Given this list of marker genes USPL1, RNF167, HMGB2, PIP4P1, ARHGEF9, AASS, EXOSC3, TPM3P9, SNAI2, EIF4A1P7, SPATA13, NIF3L1, ZNF569, TPI1P2, TXNDC12, IMP3, IFT27, SEC63, RHOA, MAP3K3, MBIP, CCNT2-AS1, FOXC1, NCAPD2, NGDN, RGMB, WDR81, PIK3R3 (phosphoinositide-3-kinase regulatory subunit 3), KHSRP, H2BC5, TNFAIP8, EN1, HCP5, PSMC4, NOP16, MAP3K13, PPP2R1A, NME1, WDR36, EXOC4, CASP8AP2, ENSG00000255240, ATF2, PGD, BEX4 (NCBI Gene Id 56271), CCDC51, MPC2, NME1-NME2, YIF1B, CREB3L4, DRC12, STX16-NPEPL1, SLC38A2, ST6GALNAC2, PAPSS2, PTTG1, RBBP4, HSPB6, AAMDC, RBM4, MSTO1, COPS4, RPL5, MAP3K9-DT, VPS51, ZNF302, CERNA3, LINC02939, UBE2D3-AS1, ATF7-NPFF, UBP1 (NCBI Gene Id 7342), LINC00240, TCP1, WDR62 (WD repeat domain 62), ZC3H12C, MIR933, DDX5, SLC25A25, SPTLC1P1, KDM3A, ZNF217, MTMR4, POC5, PHTF2, EFCAB11, TNFRSF10B, ST20, IER5L, IDI1, LINC01013, PSMA1, APOBEC3H, NEDD9, MRPS14, SSX2IP, TEPSIN, ZNF700, MGAM2, SNAI3-AS1, ABCA11P (ATP binding cassette subfamily A member 11, pseudogene), MTRF1L, LINC00173, C16orf95-DT, BPGM, SNHG19, LENG8-AS1, SRSF1, GABPA, RND1, KIAA1586, RBM15-AS1, MAP3K7, RAB5B, FAM228B, RFX1, PMS2P4, MTF2, SLC12A2, TOP2A, IFIT1, IVD, KCTD5, ADAMTS17, CCDC71L, MYO19, LINC00910, IBTK, ZNF714 (NCBI Gene Id 148206), NLK, ZNF678, C1QTNF6, HOMER1, TOMM20, MED23, STAG3, COX17, LINC01596, RGMB-AS1, ETV4, RPS24, PDP2, MTND4P34, PSENEN, XBP1, RRAGAP1-AS1, RTTN, CDKN2D, PQBP1, COMMD4, UNK, BRIP1, MXD3, OGG1, MEIOC, TMA7, ZNF221 (NCBI Gene Id 7638), TNKS, RNU4-71P, KCNC3, ILF3 (interleukin enhancer binding factor 3), EGLN2, HACL1, ACSF2, ARL15, ZNF138, SPTBN4, SMAD6, PHPT1, TRMT10C, YJU2, CCNB1IP1 (cyclin B1 interacting protein 1), DLX6, PDXP, RBM42, TRIR, GNAI2, RNU5E-4P, ZDHHC24, MCM3AP, NSUN6, MSH3, NME7, HLA-F, RPL37, BAZ2B, RMI1, BAG2, GBF1, SNORA21, LYPD6, FAM76A, PRRG2, PLEKHG2, PRRT2, PPP6R3, TNPO3, LINC02356, PMEL, NFIA, MALSU1, SNHG10, RAB27A, CBLB, PTK2B, EPHX1, ZNF611, ENSG00000207751, ATF7IP2, TIMM17B, CCAR1, ZNF232, PCLAF, TMEM60, ZNF117, PXDC1, ZNF416, ZFP28-DT, ANAPC5, RPS19, UBASH3B, TMX1, LINC01232, CNNM3, LRP10, TNFRSF10D, CEP57, TBC1D31 (NCBI Gene Id 93594), NLGN2, SPTLC2, SCOC, NKX3-2, TJP3, SNAP47, MAFB, DHFR, ZNF93, ARL2BPP3, FKBP14, SRGAP3, CLCN3 (chloride voltage-gated channel 3), CDK19, PAXBP1, LGR4, FAM13A, RNU7-1, SLC25A11, ZNF230-DT, SF3A3, ZDHHC12, H2AC25, MEX3C, FBXO8, STAG2, ZNF91, MAEA, MAGOH-DT, PHETA1, GPHA2, LGALS1, NANP, CDK11A, ILF3-DT, YPEL5, DNAAF3, ENPP3, INTS14, DBF4B, MMS22L, TARS1, COMMD6, OS9, ABHD8, TRIM68, AURKAIP1, VTRNA1-1, AKNA, AMBRA1, EXTL3, JPX, SH3BGR (NCBI Gene Id 8211), C11orf24, POLR1C, ZNF670-ZNF695, FAM114A2, CCDC82, ACTB, SEC22C, GPR137, TIGD5 (tigger transposable element derived 5), LINC01572, ARID3B, THAP10, WBP1L, DTL, ZNF565, FAXDC2, KIAA1217, ZNF799, MYL1, ING1, SIAH2-AS1, FAM111A-DT, UQCC5, CIC, CD83, ZNF737, MT-TT, ASF1A, SLC24A1, BTD, SPRYD3, ALDH1A1, CCKBR, C16orf95, PGM2L1, STXBP5-AS1, MTMR9, DNAAF6 (dynein axonemal assembly factor 6), SNRPA, ALDH6A1, CBX5, ID1, CYP2R1, CFLAR, UPRT, GPATCH2, BAZ2A, AGPAT1, LETMD1, COX16 (NCBI Gene Id 51241), RHEB, KANSL1, GLUD1P2, GRN, UTP6, RPS11, SAMTOR, FBXO5, RPS7, PIGBOS1, POLR2B, XPO1, MATN1-AS1, FAM43A, MGC16275, CENPU, SP2-AS1, CCNK, MLC1, CSTF3, SOD1, ITSN1, PRDX5, HYKK (hydroxylysine kinase), EIF3H, ELL, PLK1, USP30, LINC01746, LINC01569, MZT1, GDI2, LINC00665, LINC02562, WDR37, STRIP1, TMEM256-PLSCR3, OLIG1, TES, KPNA4, MED18, TPRA1, KAT5, C12orf57, OXSR1, HS3ST3B1, DUSP6, MPRIP, PLAUR, MSANTD4, SOCS5, SF1, STPG1, FBXO27 (NCBI Gene Id 126433), ZNF292, ENSG00000271860, GALNT9-AS1 (GALNT9 antisense RNA 1), CDKN2AIP, DUX4L18, TBC1D12, TM2D2, TP53BP1, MCM6, ZNF232-AS1, RAB3A, CDV3, IGF2BP3, MPP2, BTF3L4, USO1, TMOD1, ID4, TMEM242-DT, SOX9, ST20-MTHFS, MIR191, TMEM30BP1, SESN3, DNAJC8, PDE4D, ZNF606-AS1, ANO10, EIF3F, ZNF443, ZNF680, PPIL3, MRPL44, EMD, TNRC6B, ERF, MRPL51, ZNF570, CYBC1, APLP1, KDSR, AKT2, FAM117B, PROSER3, TRAF4, LINC02615, ZRANB3, NDUFA11, SERINC5, SOX9-AS1, NOSIP, CD101-AS1, MT-TE, LINC02987, PRKACB, ZNF432, THAP7, LENG9, LINC02889, MFAP3, FNDC3A, LRRC17, ATP5MC3, PWWP2A, PPP1R3F, ZBTB5, BRCA1, CCDC115, YPEL3, OR2I1P, MCCC1, SETD3, SP1, ANP32E, TUBGCP6, DERL3, CDC5L, TRIM37, SLC1A3, SETD5, ERC2, GTF2H4, NDUFB11, LIN52, HLCS, ALPK1, TOP3A (DNA topoisomerase III alpha), LRCH4, LINC02506, HMGN1, MAD2L1BP, GAS7, INTS3 (integrator complex subunit 3), TUT1, RAD52, AP3M2, ZNF107, TRIB1, GRB2, ANKHD1, FN1, ALG5, MARCHF2, PAAF1, CDCA2, LIPG, ENSG00000267698, TBC1D22A-DT, EVI5, PEX13, SLC39A1, DGUOK, NAE1, CEP44, CKS1B, FANCM, FBXO21, ZNF441, BRPF1, MCM3, NRBF2P5, RANBP3L, PSMD11, DIPK2A, MICB (MHC class I polypeptide-related sequence B), MAGI3, ZBTB40, TRAF3IP2-AS1, HMGN3, ZNF766, COQ8A, SAP30BP, RPA2, WBP1, SLC9B2, NUDT15 (NCBI Gene Id 55270), SP2, MIR301B, ENSG00000224478, RNFT1-DT, CDR2L, ESRRB, ARL4D (ADP ribosylation factor like GTPase 4D), NFYC, HLA-A, PUS10, NPC2, GLTC1, NTPCR, ENSG00000260132, LAMTOR4, AOC1, JAKMIP2, IGFLR1, FEZ1, USP1, SSBP1, PPP2R5C, LINC02598, DMAP1, INTS13, OLMALINC, TMEM185B, DNAJB4, SCOC-AS1, MEOX1, H2BC21, ARID1A, TTF2, BMS1, ZNF566-AS1, BTN2A2, CAPS2, PIGW, TRIM24, MIR4470, HLA-DPB1, CFAP144, GBA1LP, BORA, DNAI3, XIST, DAPK3, LMAN2, ZNF451, CCDC117, UNKL, PAX6, TMX2, PRR14, ZNF136, MAGOHB, HNRNPUL1, BCL2L13, PARP4, NEU1, TUBA1A, KIAA0408, NUCB1, TAGAP-AS1, CALR, TDP1, HLA-C, MED29, ECH1, NUP62CL, SPAG4, ANKRD27, HERPUD1, ZNF286A, CENPA, EXOSC8, RNFT1, DEPP1, LYRM7, TTC4, AK2, TTC14, RPL36, ETV5, VAMP1, PFKFB2, SLC39A9, CCNI2 (NCBI Gene Id 649438), COL9A3, RNU2-2P, MAN2C1, SUCLA2-AS1, CDK5R2, ENSG00000259588, OTUD6B, PPIG, COA6, SFT2D3, RGL2, ZBTB22, MT-ND6, DEDD2, NCOR2, MIR22HG, GDF11, PRRC2A, DBP, PDK4-AS1, PCNT, MAU2, HCG25, POLE3, MCM5, WTAPP1, MAGOH, ATP4A, PGAP2, EIF2B2, SNHG3, MRFAP1L2, PSAP, CFAP20, ENSG00000232995, FAM168A, AKIRIN2, ICAM5, ZNF841, MIGA2, LZTFL1, ILVBL, ZNF780B, POGLUT2, TRADD, CA5BP1, CIBAR1, PANK1, PANK3, C19orf38, UCHL5, SPAG9, COA4, TMCO1-AS1, LINC02960, TRIM38 (tripartite motif containing 38), YOD1, RN7SL525P, ITGB1BP2, RPS6KB1, PIN4 (NCBI Gene Id 5303), ATG2A, SYCE3, ZNF26, ANKRD13A, DCXR-DT, FZD2, TSC22D4, PSCA, FBXO16, ENSG00000261697, ZNF783, NRBF2, GLDC, LRRC27, PTPRO, SLC35F2, CSNK1G3, EIF2AK3-DT, PHF14 (NCBI Gene Id 9678), MPP7, SPATA17, CDK12, NDUFS8, CHFR, TUFT1, GLRX5, KDM8, RPL23, DMRTA2, CCDC61, TMEM30A, RNU5A-8P, LYSMD1, LINC01585 (long intergenic non-protein coding RNA 1585), AGO3, CCHCR1, ATP5IF1, MAML1, PTMA, RNU6-914P, UTP3, MICOS13, TBX18, NDUFAF3, XPC, DHX8, CHD8, ZNF718, GOLGA6GP, TERC, NABP2, ANKHD1-DT (ANKHD1 divergent transcript), NUP43, GPC2, MIR4479 (microRNA 4479), PHC1, SF3B6, RCC1, HSPE1, TMA16, EIF3K, TMSB10, SPOCD1, CBR3-AS1, KMT5A, CS (NCBI Gene Id 94822), PLCL1, SDHAP3, SPRY4, TCERG1, SNRPB2 (NCBI Gene Id 6629), STOX2, RAI14, TMEM242, C9orf43, GNA12, KRT38 (NCBI Gene Id 8687), ZNF8-ERVK3-1, ABHD2, ZNF114-AS1, TMED1, PPIP5K2, PNPO, MRPS9, ADPGK, HDAC6, SHPRH, C1GALT1, TBCB, TUBA1C, NCOA4, GCAT, CYB5B, RNU1-19P, SELENOI, TRAV10, CDK1, HNRNPH2, CREB5, AVPI1, EPCIP-AS1, NR2C2AP, COPS7B, INTS7, ZNF182, TICRR, CCNC, TRAF7, EMC10, CRK, ZNF875, MTND4LP24, KDM4A, LINC02593, NIPAL3, TMEM209, NBR2, H4C4, RHOF, POLR3GL, BAG1 (BAG cochaperone 1), TVP23B, TMEM45A, SDR39U1, TEKT1, SMCR8, TRIP4, CHD2, LARP4, ANGEL2, ANXA4, TOMM40L, ZNF708, LINC03074, APOLD1, MR1, EXD3 (exonuclease 3'-5' domain containing 3), MTFR2 (NCBI Gene Id 113115), PDXP-DT, HDGFL2, TDRKH, TARS2, COX10, MIR4794, POLR2I, ZFP28, GLMN, LYSMD3, ZNF625, CLUAP1, CHMP5, IGFL4, PTPN1, BLZF1, GNAL, UBA1, TIPIN, EHBP1, ADPGK-AS1, RPS15A (ribosomal protein S15a), ARNT, MLLT1, LRIF1, RNU2-17P, CCDC14, SPRY4-AS1, DMAC2, THOC2, SLC36A1, ZNF66, EEF1D, PRUNE2, TTC14-DT, H2AC20, DNAJC7 (NCBI Gene Id 7266), HCG14, RAB6A, TRMT112, LRRK2, PPP2R5B, CEACAMP10, ZNF670, MAP4K1, NUP98, FBXO32, COQ3, SLU7, CDK5RAP1, PDE4B, DPF3 (NCBI Gene Id 8110), PNRC1, ZNF653, CHRNB4, OXR1, NFATC3, RAB18, KANTR, HSPA1B, SMG8 (NCBI Gene Id 55181), PBXIP1, PHLDB2, ZNF764, ZNF608, NXT2, NCEH1, DKKL1, ENSG00000239137, RAB4B, CSRNP3, LZIC, ZNF253, PBX1, ZNF433-AS1, PIH1D1, ZNF675, HNRNPD, GBA1, ACTN3, GJA1, IPO4 (NCBI Gene Id 79711), GIN1, PSMB7, DROSHA, ISCA2, WEE2-AS1, GRK6, HYI, MRPL18, EIF2AK3, ACTA2, ZNF28, PDE6D, FGFR1OP2, KRR1, ISOC2, METTL13, TMEM231, GPBP1, HLA-E, ABTB3, IFT140 (intraflagellar transport 140), RGS9BP, ZNF8, ZNF564, ZNF226, TTC23, FKBP3, CYP4X1, BSDC1, IZUMO1, GRWD1, P4HB, PTH, SNORD54 (NCBI Gene Id 26795), SLF2, PSMA6, MED21, FIRRE, GALNT9, COX6B1, ADAMTSL5, WDR59, ZNF587B, TCF4, TMEM33, TMEM30A-DT, REV3L, RPL15P13, SH3RF2, ATF4, FAM83D, DCTPP1, TMT1A, FTL, ZNF599, LUZP1, MRTFA, MCUR1, BABAM1, VARS2, ZNF555, DSTN, ARL5B, ZC3HC1, RABAC1, MIA3, FN1-DT, ETV6, SPAG7, SLC11A2, ZNF326, H2AC13, H2BC26, TBX3, MORF4L2, TMEM41A, ACTL6A, PGAM1P5, RYR2, VRK3, SLFN12, ZNF44, RBM15, BLVRB, STAG3L4, VMAC, THUMPD3-AS1, GALM, CSGALNACT1, STAT2, BCL2, LINC01968, ZNF616, COX10-DT (NCBI Gene Id 100874058), ZNF143-AS1, PJA2, MCM9, TARS1-DT, NPPC, ABHD17B, GTPBP2, SPC24 (SPC24 component of NDC80 kinetochore complex), ZNF506, LINC01535, GRPEL2, ZNF605, TMEM160, NCLN, SUCO, ENSG00000272008, BBIP1, IQCN, TOMM20L-DT, ZNF219, USE1, NDUFAF8 (NADH:ubiquinone oxidoreductase complex assembly factor 8), ENSA, FOSL2, GPR158, LINC01482, ALKBH7, MASTL, MYB, BBX, NSUN4, ERGIC2, PHACTR4, ZCCHC2, TTC27, NEFH, TRIOBP, TTYH2, TNPO2, RAB39A, TMEM123, VKORC1 (vitamin K epoxide reductase complex subunit 1), FAM135A, ZNF561, DHDH, ZFHX3-AS1, GOLGB1, TMEM184C, DNAJC12, P4HA1, GEMIN8P4, LNCRNA-IUR, CCDC150, LINC02985, LDHB, ASNS, VAV3, LINC01275, IL1RAP, SUOX, DIP2C, TUBD1, SDHAF1, PKD1L2, CMC2, CTDSPL2 (NCBI Gene Id 51496), LRRC49, TMEM161B-DT, FDXR, CAND1, ASXL1, TXNDC15, RCAN1, BBS10, TOMM70, OTUD6B-AS1, EBF1, SCNM1, LNX2, GADD45A, HSPA2-AS1, ZNF829, MIR3646, NR1H2, ZNF568, ZNF519, LIM2-AS1, ERH, PTPRS, TRIM28, GOLPH3L, NDRG4, MDC1, ADAM9, RPS6, CSTF3-DT, ALDOA, FAM76B, MAP3K9, UBB, NDUFS7, PLPP7, ALKBH6, CHSY1 (chondroitin sulfate synthase 1), CRAMP1, UHRF2, DZIP1L, SUCLA2, RGS5, TRIM59, CHCHD4, SNAPC1, SFPQ, YBEY, RNU6-992P, C14orf28, CNNM2, PHF23, G2E3, ALG10B, LNP1, UIMC1, UBE2D3, YME1L1, ZNF146, UBALD2, POLA2, ZNF486, LINC01089, TCEAL4, SF1-DT, RPS20, N4BP1, GLYATL1, ZNF563, TATDN2, ZNF8-DT, NCKAP5L, COX14, VMP1, ACTMAP, ZNF131, ADAMTSL1, PCP4L1, RPL27, PRC1, DCTN4, PDK4, CHEK1, CDH1, SLC7A11, CREBL2, PTER, RAET1G, CACNB3, ZNF417, PAF1, IFI6, PSD2-AS1, DPYSL2, EPS15, RBM10, ABCC2, GALNTL5, TCTA, CENPN, HMGA1, SLC25A30, LSM8, PLEKHA8, NFYB, PRR13, MIR638, NKIRAS2, ANK3, SRF, METTL9, POLR1D, H3-3B, PPOX, SERTAD1, ZNF155, DIABLO, BPNT1, ILF2, YPEL1, EWSAT1, HSD17B12, MAPK1, SLC43A2, SNCA, MYBBP1A, SH3BGRL, PRKAB2, CBR1, RUBCN, PHGDH, ZIK1, EEIG2, FXR1, DMXL1, ERV3-1, CATSPERG, CCDC85C, ZNF833P, ABCA9, TBC1D10B, DMXL1-DT, LAS1L, ZNF436-AS1, RARB, NR3C2, AKAP11, STK17A, MIIP, ZBTB8OS, CAMTA1, SNORD60, DAPK2, NDE1, KCTD9, ATP6V1E1 (NCBI Gene Id 529), EML2, STX16, RNF6, TBC1D22A, R3HDM1, MTND3P13, DUSP7, HNRNPK, GARIN5A, SLC29A1, MAPRE1, ZNF566, TIMM44, RPL30P11, RBIS, AGPAT4, CNOT1, TMEM263, SLC26A11, NHSL1, ARHGAP28, FAM111B, PPIF, DPH1, SHOC2, C18orf21, BFSP1, MAPKBP1, CRELD1 (cysteine rich with EGF like domains 1), RHEBL1, ZNF83, DDOST, ADGRF3, MFAP3L, ASPH, CRADD, ADCK2, LINC02926, PRPS1, TLX3, SDE2, ZNF701, CENPF, MYO1B, ETV1, RSPH3, NPHP3, LTN1, FBXO24, TTC17, FDFT1, PHYH, ATP5F1B, HINT2, DNM2, SNX12, LGR4-AS1, HSPE1-MOB4, ZNF625-ZNF20, HLTF, PHF21A, SHC1, RECQL5, MIR4428, ZNF461, FBXL8, LINC02643, KLHL20, NUF2, U2AF1L4, GUCY1B1, YIPF3, STAG3L5P-PVRIG2P-PILRB, ZNF160, ABCA7, SPACA5, USP54, CPT1C, ZNF613, DALRD3, NFKBIB, RBMS3-AS1 (NCBI Gene Id 100873977), ANKHD1-EIF4EBP3, PSMB3, ZNF579, SFN, CCND3, NPHS1, NF2, PSMG3-AS1, N4BP2L2, DCXR, MTCO3P12, LINC00662, CHCHD5, RSPH4A, HSPA2, CNPY3, H2AC6, RUNDC3B, NME9, RO60, ASAH2B, GRPR (NCBI Gene Id 2925), ZNF721, ZNF143, LINC02073, BIRC3, RGS4, GRPEL1, DDX55 (DEAD-box helicase 55), PAK4, RAP2B, SOD1-DT, WDR24, TRIM11, RAP2A, ZNF71, BIVM, RAB4B-EGLN2, GPR180, DNAJA1, G3BP2, SLC39A3, PNRC1-DT, ZNF85, MORC3, SULF1, PTRH2, STAG3L5P, MTOR, CAMTA1-DT, STK40, GRB7, UBE2T, ESYT1, ZNF493, SSB, HSPD1P9, ZNF140 (NCBI Gene Id 7699), MDN1, LINC03067, MTR, PKM, PCYT1A, GTPBP3, C5orf22, C9orf72, UBC, INPP5B, MTND5P11, NATD1, SEC1P, HDAC8, FRYL, HNRNPA1, ZNF765, KCNAB2, ZNF286A-TBC1D26, LCA5, JMJD4, ZNF227, TMEM161B, TTLL5, HMGB1, LENG8, SLC26A2, DDX50, TRIM35, RPL29 (NCBI Gene Id 6159), RN7SL41P, SELENOP, APTX, ZNF695, CARD8 (caspase recruitment domain family member 8), C21orf58, H2BC13 (H2B clustered histone 13), ANKRD54, HNRNPD-DT, KAT8, TXNIP, TSC22D2, BORCS7, NMNAT1, PUM3 (pumilio RNA binding family member 3), HMGCS1, TESK2, ELAVL2, IMP4, USF3, KIFAP3, ZNF114, TMEM256, ZNF337-AS1, LINC02851, FAM222B, ZNF726, NBR1, COX8A (NCBI Gene Id 1351), ZC3H6, S100A11, JPT2, ZNF575, CDK16, ATF7, CEP95, PSMD3, DHTKD1, SNORD59A, CA13, CTDSPL2-DT, AP2S1, ATP5PF, TCF19, CAT, MFSD14A, MVB12A, ZNF480, MTHFD2, MORF4L2-AS1, CIT, KAT6B, TRIM59-IFT80, NOXA1, TMBIM6, COA6-AS1, SLC12A2-DT, METTL17, CCNT2, FRRS1, GLA, SIRT2, ZNF808, TROAP, C9orf85, EVI5L, FBRS, PEX11G, BTN2A1, ZNF284, DOHH, MMP11, HMGN5, MYL11, VPS26C, TACC2, CHD4, CHCHD10, TTN-AS1, MIR548AL (NCBI Gene Id 100616215), MNT, MBNL2, THAP7-AS1, MT-ND4, HMGN2P46, TDRKH-AS1, HSPD1 (heat shock protein family D (Hsp60) member 1), TMEM184C-DT, RNU6ATAC, MAT2B, SUGP1, HSD11B1L, LINC02202, MIEF2, TRAF2, FBLN5, ABCG1, GRAMD2B, DCAF6, NAA35, CRYZL1, ABCD2, TMCO1, MCL1, JRK, LIPE-AS1 (LIPE antisense RNA 1), CYTH2, FREM2, WDR74, ATF7IP, ENTPD1-AS1, ZNF433, ZNF706, ZNF761, MVD (mevalonate diphosphate decarboxylase), here is a description of the gene set: from publication Yevshin I, Sharipov R, Kolmykov S, Kondrakhin Y, Kolpakov F (PMID 30445619) Human Gene Set: ZNF350_TARGET_GENES studied in species Homo sapiens Genes containing one or more binding sites for (ZNF350) in their promoter regions (TSS -1000,+100 bp) as identified by GTRD version 20.06 ChIP-seq harmonization.